Given this list of marker genes Ldlrap1, Spr, Rdh10, Itga2b, Bst2, Slc25a22, Rbm38, Fbxw9, Gtpbp1, Mapkapk2, Celsr2, Slc31a1, Tob2, Gpha2, Uhmk1, Ptprm, Eif1a, Ggta1, 2310022A10Rik, Mxd4 (NCBI Gene Id 69247), Plk3, Nmi, Wfdc18, Dpcd, Tut7, Morc4, Lrrc14, Oser1, Ces2g, Col17a1, Jup, Dok4, Sp110, Atp13a2, Mycbp, Hgsnat, Plcb3, Tubb4b, Krt5, 1600014C10Rik, Gusb, Cstb, Impact, Tnpo2, Acad11, Cycs, Actr1b, Zfp296, Taf13, Itgb4, Wdr45, Ak4, Incenp, Dolk, Mrps25, Crabp2, Esrra, Ada, Polr3d, Cx3cl1, Elapor1, Pex26, Tnni1, Tpcn1, Nat9, H2bc23, Adamts4, Becn1, Ifi35, Zfp97, Padi3, Dnajb1, Litaf, Tspan33, Nmnat1, Bmal1 (NCBI Gene Id 11865), Inpp5b, Col18a1, Zfp948, Jpt1, Il24, Med28, Prkra, Ube2v2, Efnb2, Psrc1, Tcstv1a, Pde12, Slc25a29, Dnajc18, Efna1 (ephrin A1), Sgk2, St14, Crlf1, Gna13 (NCBI Gene Id 14674), Pole3, Sgf29, Irgm2, Abtb1, Slc19a2, Scmh1, Capn1, Cxcl2, Cdk5r1, Myo1h, Ero1b, Krt14, Atp6v1d, Siah1b, Mid2, Dleu2, Pdlim5, Trim7, Mrpl28, Herc1, Oas1e, Pctp, Ugt1a2, Vps18, Tspan13 (tetraspanin 13), Ppm1m, Ces2e, Tgm2, 4833445I07Rik, Pex6, Cbarp, Mark4, Sbk1 (SH3-binding kinase 1), Ifi203, Icmt, Naa35, Flcn, Ece1, Pygo2, Wnt7b, Smox, Eno2, Adam8, Cltb, Sf3a1, Zfyve21, Gpld1, Cdk18, Znrf2, Ninj1, Map2k3os, Rassf5, Skp1, Rgn, Trim11, Hsd17b4, Pfn2, Adam15, Dctn3, Sh3glb2, Rabgef1, Purg, Stat1, Patz1, 9130401M01Rik, Ggnbp2 (gametogenetin binding protein 2), Alox12, Tmem158, Tmem19, Ctse, Trim17, Rnpep, Bcl2l2, Rap2a, Dcaf1, Polrmt, Ak1, S100a13, Ndrg4, Pnp, Fah, Stat2, Acsl1, Foxq1, Scnn1a, Trim32, Zfp503, Polr2a, Casq2, Otub2, Slc25a25, Fbxl20 (NCBI Gene Id 97750), Camk2b, Marveld1, Sap30, Sirt1, Wrap53, Plat, Dbt, Rbl2, Hexim1, G3bp1, Gtse1, Tapbp, Slc9a1, Pgrmc1, Hs6st1, Tnfrsf22, Mettl6, Slain1, Rhbdd3, Sp100, Rtraf, Fam117b, Zfp65, Plk2, Tnfrsf18, Cabyr, Erbb3, Pias3, Gata3, Zfp185, Bag1 (NCBI Gene Id 12017), Thyn1, Sncg, Nudt22, Gsn, Oas1d, Inca1, Aldh4a1, Msrb1, Dcaf4, Ecm1, Cavin1, Nip7, Gna15, Akr1b1, Usp2, Degs1, Rusc1, Ddit3, Pak1ip1, Tbx2, Unc5c, Hba-a1, BC023105, 1700088E04Rik, Ugt1a10, H3c14, Stim1, Tmbim1, Sp6, Klhl42, Col4a4, Mgat2, Cd274, Cldn9, Tcstv2a, Gde1 (glycerophosphodiester phosphodiesterase 1), Psapl1, Rcan1, Zbtb8os, Tlr2, Fosl1, Lgals9, Tbc1d24, Tiparp, Ppp2r5d, Rfng, Kctd12, Clba1, Eaf2, Tap1, Hap1, Gadd45a, Slc25a42, Acad8, Spa17, Apobec1, Fdxr, Midn, Ppp6r3, Smim7, Eeig1, Dbr1, Elf3, Kif22, Sord, Sephs2, Blcap, Gnl2, Denr, Mx2, N4bp2l1, Igsf8, Ddr1, Tbc1d8, Lrwd1, Rrp9, Fa2h, Vwa7, AI661453, Gsto1, Mak16, Timm22, Rab43, Rnf103, Nr4a1, Spc25, Chmp1b, Ifi47, Ddit4l, Ren1, Angel1, Mx1, Napa, Idnk, Aldh1a1, Atf3, S100a3, Zkscan14, Tmc6, Sdhaf1, Rabepk, Cpt2, Ccng1, Gcdh, Lif, Rxrb, Nfkbie, Zfp346, Tnfrsf21, Irf7, Gpank1, Junb, Ppm1a, Ei24, Pde4dip, Ubn1, Sh3bgrl3, Pdlim7, Tspan7, Bet1l, Upf3b, Ivd, Cdipt, Vps37b, Clcc1, Slc66a3, Parg, Procr, Nop16, Ifih1, Tesk1, Srf, Rnf135, Oas2, Pdcd6ip, Gtf2b, Ly6d, Slc18a1, Mxd3, Ino80b, Zftraf1, Gsta4, Rhod, Gss, Cxcl1, Glrx3, Nudcd2, Sgca, Coro2a, Isg20, Thbs1, Entr1, Rpusd1, Creld2, Pnpla2, Tfcp2l1, Dffb, Ppm1b, Nfyb, Plpbp, Ovol1, Helz2, Tgtp1, Pls3, Btg1, Dnm2, Cdc25a (cell division cycle 25A), 2510039O18Rik, Shisa2, Oplah, Mthfr, Tacc3, Cysrt1, Plxnb2, Otud5, Ube2f, Tmem132a, Clec4g, Tnfrsf23, Ddx39a, Siva1, Ik, Lrfn1, Aloxe3, Slc12a9, Pdpk1, Ankrd17, Ola1, Mpp4, Mapre3, Gbp7, Mapk9, Tmem38a, Ogfod2, Exosc9, Prss8, Slc20a1, Cyp2f2, Cbr2, Ccdc117, Tmem41a, Znhit3, Arap1, Ppa1, Slc39a4, Mdh1, Gpn3, Recql4, Ifi211, C1s1, Ulk1, Dgka, Atp6v1b2, S100a1, Epm2aip1, Opn1sw, Drg2, Mfge8, Trp53inp1, Clasrp, Sirt7, Fam216a, Rnf4, Etfdh, Sh3yl1, Sap18, Mafg, Comp, Tgoln1, Ptp4a1, Dapk1, Cd207, Sgpl1, Trim30d, Lrr1, Ifit3, Pitpnc1 (phosphatidylinositol transfer protein, cytoplasmic 1), Irf6, Cimip3, Stx3, Usp18, Crot, Cd14, Esrp2, Piwil2, Inhbb, Hsbp1, Aamdc, Siah1a, Wsb2, Galm, Slc12a2, Slc35a5, Abhd4, Npc2, Ttc39b, Ube2e1, Mcee, Crb3, Plaat3, Lpgat1, Ftsj3, Trim12a, Scn1b, Tor2a, Rnf181, Cdc42ep3, Zbp1, Cetn2, Flvcr1, Zfp385a, Dpp7, Tmcc2, Grina, Ugt1a9, Aldh2, Sh2d3c, Cirbp, Gdf15, Drc3, Dusp9, Pom121, Rb1, Ankrd10, Rogdi, Eif4ebp1, Trmt5, Arl16, Mlf2, Ncoa4 (NCBI Gene Id 80428), Zfp36, Csf3, Pgf, Tpp1, Ifi202b, Ccl2, Sdc1, Pstpip1 (NCBI Gene Id 19200), Susd6, Scarb1, Folr1, Cldnd1, Rhbg, Hras, Clp1 (CLP1, cleavage and polyadenylation factor I subunit), Cxxc5, Carhsp1, Prcp, Chac1, Stac2, Ahnak (NCBI Gene Id 73726), Ifngr2, Calhm2, Abcb10 (NCBI Gene Id 97438), Ufsp1, Gtf2a1 (NCBI Gene Id 83602), Pkp3, Mob2, Hyal1, Tcstv3, Naa80, Lrrc56, Ppp1r15a, Lgals3bp, Islr, Hpn, Obox1, Cops9, Dcbld1, Nfatc2, Crkl, Ficd, Srr, Chchd10, Rap1gap, Emc4 (NCBI Gene Id 68032), Rcn2, Serpinb5, Slc30a1, Camp, Idh1, Ergic3, Phgdh, Atp6v0b, Stard10, Xab2, Acot6, Lcmt1, Gstz1, Zfp943, Plin2, Fosb, Src (Rous sarcoma oncogene), Tbc1d1, Zfp764l1, Slc66a2, Zfp958, Rxrg, Mtfr1l, Csf1, Usp20, Acadvl, Rida, Pvalb, Lig3, Tango2, Uba7 (NCBI Gene Id 74153), Slc12a7, Serpine2, Apol9b, Natd1, Syvn1, Zc3h12c, H3c4, Vax2, Clstn3, Pigf, Surf4, Mtfr2, Dnajb9, Hspa1b, Apaf1 (NCBI Gene Id 76129), Tmem140, Wsb1, Ypel5, BC005624, Pfkfb2, Traf4, Drap1, Zfp622, Utrn, Ssx2ip, Gfer, Plekhg6, Mdm2, Exoc8, Agpat5, Capg, Adgrl1, Pmm1, Eif3b, Fyttd1, Isyna1, Itm2c, St6galnac4, Cxcr4, Ikbke, Itpka, Prkrip1, Mcfd2, Psmf1, Ric8a, Ykt6, Sphk2, Nherf2, Slc37a2, Cited4 (NCBI Gene Id 56222), Hsd11b2, Arrdc1, Masp1, Crem, Coro1a, Hmg20b, Plekha3, Trabd, Klhl25, Wipi1, Ncoa1, Alkbh4, Angptl2, Vasn, Cdkn1a, Pdcd10, Atp6v0c, Ptger4, Cby1, Col11a2, Gbp6, AI837181, Eif4e3, Dab2, Spryd4, Rnf128, Ubald2, Tepsin, Ugt1a6a, Trex1, Rbm15, Hbegf, Rnf14, Cpeb4, Dnajc9, Shmt2, Cep104, Hyal2, Gbp2, Itga6, Klf17, Prkcd (protein kinase C, delta), Zranb1, Ahcyl2, Pnpt1, Cldn23, Ccdc86, Myd88, Zfand2a, Btg2, Omp, Slc45a3, Ctr9, Fbxw4, Mlh3, Dnaja1, Ugt1a1, Trim41, H2-T10, Cenpt, Tcirg1, Fos, Acaa1b, Slc25a44, Agtpbp1, Apoh, C1qtnf1, Egr2, Smim3, Ptpn11, Gga2, Ino80e, Wdr46, Ift27, Spon2, Osgin1, Stau1, Foxj1, Ehd1, Slc25a33, Galnt3, H2bc4, Plec, Rgcc, Nt5dc3, Ndufa11, Inpp5d, Cracr2b, Mavs, Cul4a, Fam43a, Rhpn2, Lmbr1l, Nop9, Hagh, Skic8, Ogfrl1, Jak3, Rnaseh2c, Pstpip2, Nopchap1, Tmem184b, Kcnk2, Dram1, C4b, Polk, Oasl2 (2'-5' oligoadenylate synthetase-like 2), Ier5, Gem, Pla2g12a, Snx2, Tamalin, Tmed5, Il6ra, Ifi30, Gpaa1, Kif17, Desi1, Dmpk, Usp17la, Sfi1, Nub1, Ptger1, Cd24a, Ube2o, Dgkq, Ephx1, Emp3, Sidt2 (NCBI Gene Id 214598), Fam8a1, Sox4 (SRY (sex determining region Y)-box 4), Ugt1a5, Gpr146, Hmga1, Zfp703, Rap2b, Irak1bp1, Slc12a4, Lancl1, Lpin1 (lipin 1), Btg3, Ifnz, Kifc3, Plek2, Trafd1, Rflnb, Rdh5, Atg9b, Ckap2, Mitf, Acox2, Mal2, Egr1, Map2k3, Mustn1, A630072M18Rik, Il15 (NCBI Gene Id 16168), Ap4s1, Smpd4, Slc35d1, Man2b1 (mannosidase 2, alpha B1), Tmem150a, Hes6, Frmd8, Scin, Icam5, Tuba4a (tubulin, alpha 4A), Gkap1, Cmpk2, Il17d, Upp1, Myo5a, Entpd7, Iigp1, Marcksl1, Celf4, Yipf2, Gch1 (GTP cyclohydrolase 1), Arap2, Armc7, Hhatl, Inava, Rnf225, Cd68, Mmp15, Pm20d1, Adamts7, Ube2t, Cenpe, Il4ra, Gorasp1, Slc6a8, Tor3a, Cxcl10, Slc10a6, Acad9, Efnb3, Arvcf, Septin3, Chp1, Ppp5c, Tuft1, Igtp, Gipc2, D6Wsu163e, Slx9, Ptrh1, Pitpnm1, Nacc1, Atg3, Ctsl, Arf2 (NCBI Gene Id 11841), Ccpg1, Gpd1, Cpox, Atox1, Rbm4, Shisa5, Leng1, Eola1, Sh3bgrl2, Zbtb8a, Serinc3, Klf5, Glud1, Xrcc1, Ifi44, Klc2, Slc39a7, Znrf1, Fetub, Mcl1, Wipi2, Depdc7 (DEP domain containing 7), Cntrl, Ikbip, Zfp960, Acadsb, Pitpnm2, Zfp738, Ahr, Prkd2, Stard5, Klhl10, Bcl2l11, Gbp4, Dnajb2, Pdlim1, Tkfc, Eed, Tgfb3, Dph7, Cited2, Ripor1, Atg101, D16Ertd472e, Pdrg1, Gsta2, Gtf2ird2, Il18, Sac3d1, Ccs, Nptx1, Gfod2, Glcci1, Sesn2, Nat8f4 (N-acetyltransferase 8 (GCN5-related) family member 4), Fkbp9, Tra2a, Slc27a1, Usp17lc, Dgat2, Kctd10, Tlr3, Mafk, Glul, Ccnl2, Fam110a, Ccdc96, Lmo4, F11r, Nbeal2, Pla2r1, Epha2, Caprin2, Ttll1, Atp6v0e2 (NCBI Gene Id 76252), Tmem51 (transmembrane protein 51), Cbx1, Hexb, Pde1b, Lrrc57, Gns, Pdxp, Dop1b, Cep112, Nt5dc2, Dusp6, Sf3b5, Bcar1, Cdhr4, Ccdc137, Gcc1, Ube2i, Tcf7, Psme3ip1, Usp27x, Fuca1, Atp6v1e1, Tm2d2, Ifit1, Crip2, Macrod2, Lztr1, Strap, Ppcs, Areg, Gcnt2, St3gal2, Ttc16, Arpp21, Phlda3, Atp6v0d1, Fam83h, Dcxr, Map7d1, Alad, Slc35f6, Psmb9, Zap70, Ttc27, Baiap2, Fcgr4, Trim30a, Srp14, Ercc5, Pthlh, Spns1, Extl1, Cotl1, Fzd7, Mtarc2, Rgs16, Mapre1, Ralgps1, Fzd5, Pml, Eif2b2, Daxx, Ninj2, Bmp1, Rtp4, Fam50a, Oas1c (NCBI Gene Id 114643), Gpat4, Atp6v1c1, Trim34a, Unc119b, Aldh1l1, Haus2, Aen, Ptprv, Oas3, H1f2, Usp38, Kdm5b, Vegfa, Cdr2, P2ry6, Slc33a1, Fez1, Bcap31, Fgf18, Idua, Noct, Adamts15, Mphosph8, Hacd2, Crat, Rad9a, Hmox1, Top3a (NCBI Gene Id 21975), Sgpp1, Ttc13, Ptpn1, Klhl22, Ctsb, Ifi204, Elovl7, Srms, Efnb1, Irgm1, Itpa, Msh6, Psmc3ip, Hr, Nlrx1, H2ac25, Rps27, Isg15, Spint1, Tmod1, Ggct, Nid2, Urm1, Rab11fip5, Retsat, Mapkbp1, Dstn, Zfp426, Pa2g4, Aox1, Tecpr1, Acox3, Fhl2, E2f1, Atosb (atos homolog B), Eogt, Sap30bp, Kctd11, Cep295nl (NCBI Gene Id 58251), Stk17b, Alas1, Mmd, Mr1, Aqp1, Rragc, Lrrc51, Parp12, Lhx2, Ifitm10, Angpt4, Ppp1r37, Rsad2, Ufd1, Capn10, Pmpca, Dhx58, Snx16, Apof, Plekha4, Nxn, Mafb, Has2 (NCBI Gene Id 210441), Zmiz2, Pdgfb, Ampd2, Nanos1, Ppif, Jade1, Ltbp2, Brix1, Spsb1, Herpud2, Ehd4 (NCBI Gene Id 99247), Larp1b, Qsox1, Rnpc3, Rabgap1, Tm2d1, Adam1a, Endog, Wfs1, Pkdcc, Rab40c, Fbxo33, Ippk, Zfp593, Uggt1 (UDP-glucose glycoprotein glucosyltransferase 1), Arhgap27, Lactb (lactamase, beta), Spef1, Trim21, Adrb2, Trp53inp2 (NCBI Gene Id 68728), Simc1, Zfp281, Dexi, Asah2, Fbrs, Slc35e4, Moap1, Exoc4, Evi2a, Lrrc8a, Tk2, Tead3, Hoxa5, Srxn1, Fgfr4, Lynx1, Slc7a7, Pkp1, Gtf2f2, Rpe, Map1lc3a, Ldb3, Trpt1, C1qtnf5, Padi2, Ass1, Lman2, Josd2, Cdr2l, Ly6a, Tex9, Tcim, Tpra1, Rin2, Abhd5, Aar2, Oas1a, Rgl1, Cnbd2, Edem1, Pcyox1, Impa1, Ddx60, Ripk4, H2-Eb1, Phykpl, Twf2, Ccn4, Sec61a1, Oasl1, Lasp1, Rbm43, Ccdc166, Msantd5f5, Selenos, Perp, Gal3st1, Rnf19b, Mfrp, Zmat3, Higd1a, Entrep3, Lbx2, Rdm1, Fas, Nmrk1, Igfbp4, Zpr1, Tmem191, Phlda2, Zfp219, Paqr4, Fam32a, Arhgap39, Nabp1, Tmem40, Rasa4, Rom1, Pdgfa, Ptgr1, Endod1, Pdk4, Smarcad1, Pla2g6, Psmb4, Dgat1, Padi1, Gpsm1, here is a description of the gene set: Impairment of the complex regulatory network of cell death and survival is frequently the reason for therapy resistance of breast cancer cells and a major cause of tumor progression. We established two independent cell lines from a fast growing mouse breast tumor (WAP-SVT/t transgenic animal). Cells from one line (ME-A cells) are sensitive to apoptotic stimuli such as growth factor depletion or treatment with antitumor agents (e.g. doxorubicin). Cells from the second line (ME-C cells), which carry a missense mutation at the p53 codon 242, are very insensitive to apoptotic stimuli. Co-cultivation experiments revealed that the ME-C cells mediate cell death resistance to the ME-A cells. Microarray and Western blot analysis showed that osteopontin (OPN) is selectively overexpressed by the ME-C cells. This glycoprotein is the most abundant protein secreted by the ME-C cells and we obtained strong indications that OPN is the main antiapoptotic factor. However, the OPN containing ME-C cell medium does not alter the expression level of pro- or antiapoptotic genes or known inhibitors of apoptosis (IAPs). Its signaling involves mitogen-activated protein kinase (MAPK)/extracellular signal-regulated kinase (ERK) kinase (MEK)1/2 as the kinase inhibitor PD98059 restores apoptosis but not the Akt inhibitor. In the ME-A cells, mitochondrial cytochrome c release occurs with and without external apoptotic stimuli. OPN containing ME-C cell medium does not prevent the mitochondrial cytochrome c release and caspase-9 processing. In serum starved ME-A cells, the OPN containing ME-C cell medium prevents caspase-3 activation. However, in doxorubicin-treated cells, although apoptosis is blocked, it does not inhibit caspase-3. This indicates that the ME-A cells distinguish between the initial apoptotic stimuli and that the cells possess a further uncharacterized control element acting downstream from caspase-3. Mouse Gene Set: GRAESSMANN_APOPTOSIS_BY_DOXORUBICIN_UP studied in species Mus musculus from publication Graessmann M, Berg B, Fuchs B, Klein A, Graessmann A (PMID 17160024) Genes up-regulated in ME-A cells (breast cancer) undergoing apoptosis in response to doxorubicin.